Given this list of marker genes C2orf69, RNF4, FAR1, LPGAT1, MFF, HADHB, CADM4, CBFB, PAPSS1, DEDD, KRAS, ACAT2, POP1, ATP6V1D, TRAPPC13, BTAF1, IFT74, ZNF655, ZNF451, NAA16, OXCT1, TM9SF3, E2F7, CAPZA1, LYPLA1, AMFR, ERN1, PBX3, SNAP23, IKZF5, EXOC5, PRICKLE3, RBM10, IQGAP1, SOAT1, YWHAZ, RSPRY1, RGN, TMEM127, ABHD18, DNAH12, ELP1, TSPYL1, KLF9, ATP2C1, ADNP2, NUP153, HSPA13, NCOA6, XPOT, TSR1 (NCBI Gene Id 55720), CDC42SE1, SPRED1, DNAJB5, FAM234A, ACVR1, UTP18, ARL6IP6, UBL3, SLC20A1, CORO7, CAPZA2, NPPA, GDI2 (GDP dissociation inhibitor 2), YAF2, RBM18, HOXD13, RBM27, GPAM, CASD1, RNF139, QKI, UBE2H, TNK2, FLI1, CTNNA1 (catenin alpha 1), AP2B1, NT5DC3, FAM20B, SLC2A1, ATF1, SNX16, AFG2A, TTC13 (NCBI Gene Id 79573), SLC33A1, STX1A, HOMER1, PAIP1, CYTH1 (cytohesin 1), SLC39A6, HERC4, FCHSD2, PHF7, ATXN7L1, SMARCD2, PIP4P2, CSNK2A2, SLC25A46, ATP11C, CHORDC1, CDC14B, HRH3, CTNNB1, AKT3, TPM3, CSTF2, BCR, NR2F6, C3orf38, P2RY10, DCTN1, ANKRD33 (ankyrin repeat domain 33), HSF4, UBE4B, DDX5 (NCBI Gene Id 1655), NADK2, TGFBR2, RNPC3, MTHFD1L, TLK1 (tousled like kinase 1), SH3YL1, CLIP1, DCK, ACOT11, ATXN10, PARD6G, SMAD3, SYNPO2, IFI35, STT3B, MSANTD4, ORC3, POFUT1, BICD2, PTPRA, LRIF1, LDLRAD3, MAPK9, KBTBD8, GPC3, SLC29A2, G3BP2, ERBIN, CPNE3, RIC8A, MGAT4B, MAPRE1, THUMPD3, MARCHF7, STYX, ZHX1, ITCH, PPP1CC, ARF1, RTRAF, MAN1A2, TIGD2, DENND4A, TRPC1, SET, TIAM1, TTLL11, KAT2B, BMPR2, INTS1, MAP3K4, SLC16A1, SERINC5, SCYL1, MTDH, GKAP1, DDX54, CNTROB, CDS2 (NCBI Gene Id 96708), RILPL1, YWHAB, CLCN6, PTPN12 (NCBI Gene Id 5782, protein tyrosine phosphatase non-receptor type 12), MAP3K1, STEEP1, ARID2, REXO4, FTO, LIMA1, FAM91A1, LSM14A, MTMR7, ADO, DR1, ACSL3, ARFGAP2, CHRAC1, NRIP2, NAB1, AREL1, DDX59, VPS8, RNF185, TOX4, ACOX1 (acyl-CoA oxidase 1), here is a description of the gene set: Human Gene Set: GSE39820_TGFBETA1_VS_TGFBETA3_IN_IL6_TREATED_CD4_TCELL_UP Genes up-regulated in comparison of CD4 T cells treated with TGFB1 versus those treated with TGFB3 and IL6. species: Homo sapiens TGF-beta3 produced by developing Th17 cells induces highly pathogenic T cells that are functionally and molecularly distinct from TGF-beta1-induced Th17 cells. The microarray data represent a distinct molecular signature for pathogenic versus non-pathogenic Th17 cells. from publication Lee Y, Awasthi A, Yosef N, Quintana FJ, Xiao S, Peters A, Wu C, Kleinewietfeld M, Kunder S, Hafler DA, Sobel RA, Regev A, Kuchroo VK (PMID 22961052)